Given this list of marker genes CD74, CCL21, NOD2, NOD1, SLC11A1, CCR7, CCL19 (NCBI Gene Id 6363), here is a description of the gene set: studied in species Homo sapiens Human Gene Set: GOBP_POSITIVE_REGULATION_OF_DENDRITIC_CELL_ANTIGEN_PROCESSING_AND_PRESENTATION Any process that activates or increases the frequency, rate, or extent of dendritic cell antigen processing and presentation.